The following is a description of a gene set: The p53 protein has been implicated in multiple cellular responses related to DNA damage. Alterations in any of these cellular responses could be related to increased genomic instability. Our previous study has shown that mutations in p53 lead to hypermutability to ionizing radiation. To investigate further how p53 is involved in regulating mutational processes, we used 8K cDNA microarrays to compare the patterns of gene expression among three closely related human cell lines with different p53 status including TK6 (wild-type p53), NH32 (p53-null), and WTK1 (mutant p53). Total RNA samples were collected at 1, 3, 6, 9, and 24 h after 10 Gy gamma-irradiation. Template-based clustering analysis of the gene expression over the time course showed that genes are either up or downregulated by at least twofold following radiation treatment. In addition, cluster analyses of gene expression profiles among these three cell lines revealed distinct patterns. In TK6, genes were upregulated, while genes were downregulated. In contrast, in WTK1 genes were upregulated and genes were downregulated. In NH32, only genes were upregulated. Furthermore, we found several genes associated with DNA repair namely p53R2, DDB2, XPC, PCNA, BTG2, and MSH2 that were highly induced in TK6 compared to WTK1 and NH32. p53R2, which is regulated by the tumor suppressor p53, is a small subunit of ribonucleotide reductase. To determine whether it is involved in radiation-induced mutagenesis, p53R2 protein was inhibited by siRNA in TK6 cells and followed by 2 Gy radiation. The background mutation frequencies at the TK locus of siRNA-transfected TK6 cells were about three times higher than those seen in TK6 cells. The mutation frequencies of siRNA-transfected TK6 cells after 2 Gy radiation were significantly higher than the irradiated TK6 cells without p53R2 knock down. These results indicate that p53R2 was induced by p53 protein and is involved in protecting against radiation-induced mutagenesis. studied in species Homo sapiens Human Gene Set: TSAI_RESPONSE_TO_IONIZING_RADIATION from publication Tsai MH, Chen X, Chandramouli GV, Chen Y, Yan H, Zhao S, Keng P, Liber HL, Coleman CN, Mitchell JB, Chuang EY (PMID 16247478) Genes up-regulated in TK6, WTK1, and NH32 cell lines (lymphoblast) in response to ionizing radiation., and this is the list of marker genes: NFE2L1, STK4, CCL4 (NCBI Gene Id 6351), JAK2, BTG2, ENO1, MDFI, MED21, DLX2, AXL, ADGRB3, AHR, SGK1, CCL21, CRAT, KIF20B, VEGFC, MSC, TLE3, MSH2, NDUFB5, KRT14, CDKN1A, TNFSF10, PLK1, TSC22D3, UBE2C, MAX, TNFAIP8 (TNF alpha induced protein 8), TGIF1, IFITM1, PLAU, KRT19, ZNF141, IRF4, BATF, TP53TG1, CCL18, KRT8, DDB2, CCNI (cyclin I, NCBI Gene Id 10983), PKD2L1, CCNF (cyclin F), RRM2B, MYC, ENC1 (ectodermal-neural cortex 1), COL6A1, PLCG2, CCL3, BTG1, PLOD3, CARTPT, NCOA3, EP300, MAP7, IL2RB, CASP1, PTN, CFLAR, PTTG1, FGFR1, XPC, NFKB2, TCF21, CCR1, CDK6, RFX5 (NCBI Gene Id 5993), CD83, ZNF274, IRF9, TRRAP, TFDP2, IFNGR1, KLF4 (NCBI Gene Id 9314), CCL20, TRAF1, ITGA2, FN1, PLAGL2, SIPA1 (signal-induced proliferation-associated 1), DKC1, CGRRF1, CCNG2, ZNF85, AKAP5, CCNK, PPM1D, TGFBR3, GRN, HBEGF, KNG1, JUNB, TANK, CD164 (CD164 molecule), HOXC5, TP53I3 (NCBI Gene Id 9540), CLK1, RELA, NFKBIE, TNFRSF8, NR4A3, TNFAIP3, CCT7, PTPN11, POU5F1, RORA, ADORA3, ARL2BP, POU3F4, CD59, ROCK1, GDF15, BIRC3, LRRFIP1, LGALS3, COL4A2 (collagen type IV alpha 2 chain), PTPN6, BBC3, RAD50, RPS6KA1, PCNA, CDKN1C, NFKBIA, CXCL10, CCT4, CCNE2, FAS, RB1, CCNG1, DUSP6, PRMT1, CD80, SMAD3, FCN3, LZTR1, KLRC2, COX7B, DPYSL3, ZBTB48, RANBP1, NFKB1, DDIT3, ATF5 (activating transcription factor 5), PTPN22, STAT5A, SNAPC2, S100A8, STAT1, CD79A